Given this list of marker genes Dctn4, Rala, Mapk14, Zmat3, Myrf, Mboat2, Sfrp4, Lmna, Gzf1, Mfsd14b, Med26, Sec61a2, Jakmip3, Pgrmc2, Alg2 (NCBI Gene Id 68599), Suclg2, Rnf216, Fsd1l (NCBI Gene Id 633268), Arhgdia, Hbp1, Gpr50, Gli3, Osbp, Rad17, Epha3, Hace1, Ankfy1, Piezo2, Zfand3, Zfp882, Snx4, Lcmt2, En2, Rab2a, Emp2 (epithelial membrane protein 2), Kcnq5, Lpin1, Pcsk6, Adcy1, 2210408I21Rik, Tmcc3, Slc35b2, Lrig1, Prkx, Vdac3, Nr3c2, Pdcd6, Zkscan3, 9330159F19Rik, Klhl17, Slc9a6, Luc7l2, Insrr, Cacng5, Pabir2, Slc40a1, Zdhhc3, Krtap4-16, Cep152, Zbtb5, Tead1, Aida, Fgfr2, Rd3, Ppara, Cask (NCBI Gene Id 236691), Dnajc1, Hepacam, Pakap, Stk36, Ccdc117, Cdk18, Miga2, Rela, Parp16, Map4k5, Nab1, Rsu1, Gpr37, Snx6, Ide, Napb, 0610030E20Rik, Gpm6b, Akip1, Chd1, Cbfb, Bach2, Zfp654, Cotl1, Asb1, Snx13, Ahnak, Ralgps1, Slc25a20, Paqr5, B4galt1, Zfp503, Cep72, Rap2b, Casc3, Socs6, Fzd8, Rbm20, Sft2d2, Hmgxb4, Anxa7, Klf13, Akt1s1, Adat1, Hdac4, Rbl1, Pde4a, Otud1, Lcp1, Pcdh8, Plxnb2, Nol4, Actb, Rcor1, Mtmr2, Abcc4, Cyld, Oxsr1, Nr3c1, Ebf3, Vps13a, Ints6l, Rfc1, Lemd3, Acadvl, Cibar1, Sugt1, Golm2, Litaf, Nxt2, Pik3c2a, Gltp, Kcnj5, Paxbp1, Gas1, Zeb1, Ccdc50, Itpr3, Entpd5, Gucd1, Tm6sf1, Shroom3 (NCBI Gene Id 52200), Miga1, Tmem129, Rock1, Pkn2, Csgalnact2, Abca2, Atrx, Rbms1, Ptpn2, Zfp608, Wdr41, Osbpl3, Spry1, Slbp, Sncaip, Fbxo30, Atp6v0a2, Myo10, Rbm24, Ccdc6, Sp1, Nfib, Otud4, Arg2, Prtg (NCBI Gene Id 235472), Slc39a9, Cntn3, Lss, Cdk4, Abhd3 (abhydrolase domain containing 3), Uba6, Rnf128, Snip1, Vdac2, Gria4, Slc31a2, Tmem134, Thsd7b, Cntn1, Frmd8, Fam219b, Slc50a1, Esp34, Sirt1, Rwdd4a, Tm9sf1, Fkbp1b, Eml6, Fnbp1l, Rbms3, AU015228, Prkd1, Fam78b, Rnf144a (NCBI Gene Id 24106), Trim14, Nrp2, Antxr2, Jazf1, Rab34, Vat1l, Osbpl6, Serinc2, Mylip, Nhlrc2, Ptpn12 (protein tyrosine phosphatase, non-receptor type 12), Fbxl7, Fbxo28, Prr5l, Rab11a, Phtf2, Usp14, Cnot7, Cbln4, Sema6d, Frmd4b, Rere, Git2, Mab21l4, Cdh11, Mtpn, Gabra6, Klf4, Ryr3, Slc4a7, C1galt1, Cdk13, Ttl, Pptc7 (PTC7 protein phosphatase homolog), Tmem178, Cdk6, Pid1, Dmxl1, Pea15a, Elk4, Enpp4, Magea10, Esrp1, Tvp23a, Itga11, Nploc4, Macc1, Reep1, Stk4, Elavl1, Limch1, Sertad3, Sox9, Sigmar1 (sigma non-opioid intracellular receptor 1), Elovl2, Yod1, Arhgap1, Tmem45b, Lrrc58, Chp1, Hipk3, Marchf8, Epn2, Morc4, Dnmbp, Triap1, Rap1b, Rufy2, Trim24, Plekhm3, Nkain2, Cpne5, Kcnk10, Zfp869, Zfp36l2, Prpf40a, Mllt3, Bmp6, Ro60, Rap2a (NCBI Gene Id 76108), Zdhhc20, Flot2, Fermt2, Kcnj2, Slc16a1, Apbb2, Nbeal2, Irf2bp2, Map1b, Bahd1, Yipf6, Rrbp1, Katnbl1, Map7, Ets1, Dicer1, Adipor2, Prkaa2, Rragd, Cpsf6, Pde3b, Eml5, Dnajc3, Capn2, Krt35, Spopl, Pgf, Ahr, Ell2, Sdad1, Acaa2, Brwd3, Rps6kb1, Cadps, Mynn, Rpia, Efcab14, Sash1, Akap5, Itga6, Pawr, Srek1, Zfp706, Tbc1d9b, Sar1b, Myorg, Far1, Rffl, Rnf214, Zcchc14, Vwa8, Rock2, Kics2, Lysmd3, Raver2 (ribonucleoprotein, PTB-binding 2), Tor3a, Golt1b, Ctdsp2, Lpp, Rcbtb2, Cacnb2, Capn6, Tex261, Fhip1a, Chst1, Samd4b (sterile alpha motif domain containing 4B, NCBI Gene Id 233033), Wipf3, Mtdh, Ccar1, Amotl1, Etv1, Ak4, Anxa11, Tacc1, Ccdc28a, Cldn5, Aldh6a1 (NCBI Gene Id 67827), Fam78a, Ammecr1, Creb3l2, E2f6, Fcer1a, Rab9b, Ccdc198, Selenoi, Dennd4c, Septin11, Fkbp15, Septin10, Ermp1, Cd164, Jakmip1, Ahcyl1, Mapre1, Tarbp1, Wasf1, Ptbp1, Zbtb39, Dennd1b, Elapor2, Slc41a2, Sp3, Cnn3, Rapgef1, Pdcd7, Mapk4, Tcf3, Foxc1, Esyt2, Slc25a13, Mitf, Tacc2, Lonrf1, Plin3, Enox1, Acsl1, Ascc2, Foxq1, Tpd52l2, Osbpl5, Magt1, Chsy1, Sh2b3, Lrp6, Top3a, Rhoq (NCBI Gene Id 80836), Hhex, Ptpn1, Cpt1a, Papolg, Raver1, Igsf11, Slc31a1, Pik3ca, Mkrn3, Jag1, Cpne8, Zdhhc7 (zinc finger, DHHC domain containing 7), Rhbdl3, Slc1a4, Atmin, Elovl5, Ist1, Lamc1, here is a description of the gene set: Genes predicted to be targets of miRBase v22 microRNA mmu_miR_5624_3p in miRDB v6.0 with MirTarget v4 prediction scores > 80 (high confidence targets). species: Mus musculus Mouse Gene Set: MIR_5624_3P from publication Chen Y, Wang X (PMID 31504780)